Given this list of marker genes Sp1, Nrp1, Abl1, Tgm2, Jak1, Il10, Gata2, Rapgef3, Pdcd6, Tgfbr2, Cdh5, F3, Emc10, Nodal, Wnt5a, Cyp1b1, S100a1, Itgax, Pdpk1 (NCBI Gene Id 18607), Vegfa, Jcad, Uts2r, Emilin2, Itgb2l, Mir24-2, Pkm, Aplnr, Tgfbr1, Angptl3, Ctsh, Hspb6, Cxcl12, Dll1, Itgb8, Mir27a, Btg1, Jmjd8, Foxc2, Serpine1, Mmp9, Grn (NCBI Gene Id 14824), Psg22, Ntrk1, Clic3, Wnk1, Zc3h12a, Slc39a12, Tek, Uts2, Pak4, Smoc2, Itgb3, Pdcl3, Dsg2, Cma1, Cela1, Prkd2, Cd34, Emilin1, C3ar1, Tjp1, Flt1, Nr2e1, Sec1, Ccl5, Lgals3, Nras, Nos3, Adm, Add1, Mydgf, Itga5, Pgf, Tbxa2r, Cxcr4, Hgf, Vegfb (NCBI Gene Id 22340), Ptgis, Smad1, Hmox1, Epha1, Cysltr2, Klf4, Pxn, Ninj1, Isl1, Cx3cr1, Il1b, Ccl11, Hmgb1, Fgf18, Mir24-1, Angpt4, Jup, Pik3cd, Gdf2, Ccl24, Stat3, Vash2, Fgf2, Mir23b, Igf2, Lrg1, Vegfc, Il1a, Eng, Mir27b, Hspb1, Mtdh (NCBI Gene Id 67154), Ghsr, Sash1, Prl2c2, Sema5a, Pik3r6, Aqp1, Tnfrsf1a, C5ar1, Plcg1, Sphk1, Tert, C3, Anxa3, Hc, Stim1, Mdk, Erap1, Nfe2l2, Apela, Rtn4, Aggf1, Ago2, Akt3, Adam12, Grem1, Cybb, Xbp1, Gab1, Sirt6, Bmper, Ccr3, Fgf1, Cxcr3, Chi3l1, Rras, Sfrp2, Tnn, Prkcb (NCBI Gene Id 319718), Hmga2, Thbs1, Prkca, Ptk2b, Runx1, Hif1a, Kdr, Ccbe1, Mir23a, Emp2 (NCBI Gene Id 223964), Cxcr2, Ramp2, Itgb2, Gata6, Rhob, Sirt1, Hk2, Notch4, Shh, Agtr1a, Tgfb1, Gata4, Prkd1 (NCBI Gene Id 18760), Hipk2, Itgb1, Tlr3, Ghrl, Acvrl1, Cysltr1, Adm2, Brca1, Fut1, Wars2, Ddah1, Hyal1, Cd40, Tie1, Ecm1, Camp, Ets1, Angpt2, here is a description of the gene set: studied in species Mus musculus Any process that activates or increases the frequency, rate or extent of vasculature development. Mouse Gene Set: GOBP_POSITIVE_REGULATION_OF_VASCULATURE_DEVELOPMENT